Given this list of marker genes USP22, KAT7, MEAF6, KAT8, KAT5, ING4, BRD1, HAT1, NAA40, JADE2, ATF2, NAA60, JADE1, BRPF1, KAT2A, BRPF3, BRCA2 (BRCA2 DNA repair associated), EP300, NAA50, ING3, KAT6A, here is a description of the gene set: Catalysis of the reaction: acetyl-CoA + histone H4 = CoA + acetyl-histone H4. Human Gene Set: GOMF_HISTONE_H4_ACETYLTRANSFERASE_ACTIVITY studied in species Homo sapiens